The following is a description of a gene set: Reactome Pathway: RNA Polymerase II HIV Promoter Escape species: Homo sapiens part of: Transcription of the HIV genome RNA Polymerase II promoter escape occurs after the first phosphodiester bond has been created., and this is the list of marker genes: MNAT1, TAF1, GTF2F2, GTF2F1, GTF2B, CCNH, TAF7L, TAF1L, POLR2J, POLR2A, TAF2, GTF2H4, TAF12, TAF11, ERCC3, GTF2E1, GTF2A2, TAF5, POLR2F, GTF2H3, TAF6, POLR2C, POLR2K, GTF2A1, ERCC2, TBP, TAF10, POLR2I (RNA polymerase II subunit I), TAF3, POLR2G (NCBI Gene Id 5436), TAF7, TAF13, POLR2L, POLR2B, POLR2E, TAF9, POLR2H (NCBI Gene Id 5437), GTF2H5, TAF4B, TAF15, GTF2E2, TAF9B, GTF2H1, POLR2D, TAF4, CDK7, TAF8, GTF2H2